The following is a description of a gene set: from publication Matzuk MM, Lamb DJ (PMID 18989307) Genes important for post-implantation and post-partum, based on mouse models with female fertility defects. species: Homo sapiens Reproduction is required for the survival of all mammalian species, and thousands of essential 'sex' genes are conserved through evolution. Basic research helps to define these genes and the mechanisms responsible for the development, function and regulation of the male and female reproductive systems. However, many infertile couples continue to be labeled with the diagnosis of idiopathic infertility or given descriptive diagnoses that do not provide a cause for their defect. For other individuals with a known etiology, effective cures are lacking, although their infertility is often bypassed with assisted reproductive technologies (ART), some accompanied by safety or ethical concerns. Certainly, progress in the field of reproduction has been realized in the twenty-first century with advances in the understanding of the regulation of fertility, with the production of over 400 mutant mouse models with a reproductive phenotype and with the promise of regenerative gonadal stem cells. Indeed, the past six years have witnessed a virtual explosion in the identification of gene mutations or polymorphisms that cause or are linked to human infertility. Translation of these findings to the clinic remains slow, however, as do new methods to diagnose and treat infertile couples. Additionally, new approaches to contraception remain elusive. Nevertheless, the basic and clinical advances in the understanding of the molecular controls of reproduction are impressive and will ultimately improve patient care. Human Gene Set: MATZUK_POSTIMPLANTATION_AND_POSTPARTUM, and this is the list of marker genes: ABCA1, FOXB1, NR2C2, FZD4, HSF1, DAZAP1, SRD5A1, B4GALT1, OXTR, CSF1, GDI1, OXT, BSX, INHBB